The following is a description of a gene set: from publication Ohm JE, McGarvey KM, Yu X, Cheng L, Schuebel KE, Cope L, Mohammad HP, Chen W, Daniel VC, Yu W, Berman DM, Jenuwein T, Pruitt K, Sharkis SJ, Watkins DN, Herman JG, Baylin SB (PMID 17211412) Adult cancers may derive from stem or early progenitor cells. Epigenetic modulation of gene expression is essential for normal function of these early cells but is highly abnormal in cancers, which often show aberrant promoter CpG island hypermethylation and transcriptional silencing of tumor suppressor genes and pro-differentiation factors. We find that for such genes, both normal and malignant embryonic cells generally lack the hypermethylation of DNA found in adult cancers. In embryonic stem cells, these genes are held in a 'transcription-ready' state mediated by a 'bivalent' promoter chromatin pattern consisting of the repressive mark, histone H3 methylated at Lys27 (H3K27) by Polycomb group proteins, plus the active mark, methylated H3K4. However, embryonic carcinoma cells add two key repressive marks, dimethylated H3K9 and trimethylated H3K9, both associated with DNA hypermethylation in adult cancers. We hypothesize that cell chromatin patterns and transient silencing of these important regulatory genes in stem or progenitor cells may leave these genes vulnerable to aberrant DNA hypermethylation and heritable gene silencing during tumor initiation and progression. Human Gene Set: OHM_EMBRYONIC_CARCINOMA_UP species: Homo sapiens Genes with a high basal transcription state in undifferentiated embryonic carcinoma cells., and this is the list of marker genes: BRCA1, DAPK1, SFRP1, CDH1, GSTP1, SFRP2